The following is a description of a gene set: A series of intracellular molecular signals mediated by TORC2; TOR (rapamycin-insensitive companion of TOR) in complex with at least Rictor (regulatory-associated protein of TOR), or orthologs of, and other signaling components. species: Mus musculus Mouse Gene Set: GOBP_TORC2_SIGNALING, and this is the list of marker genes: Tbk1, Otud7b, Sik3 (NCBI Gene Id 77161), Sesn2, Deptor, Mtor, Otud5, Syap1, Ep300, Mlst8, Prr5l, Armh4, Nckap1l, Akt1, Rictor, Mapkap1, Prr5, Gsk3b, Sesn3, Usp9x, Pik3ca, Rps6kb1